Given this list of marker genes Kcnj10 (potassium inwardly-rectifying channel, subfamily J, member 10), Naip1 (NCBI Gene Id 17947), Aqp7, Dtnb, Kcnq1, Slc7a7 (NCBI Gene Id 20540), Hjv, Ptk2, Trpc4, Slc26a5, Slc8a1, Pcmt1, Clca2, Clasp2, Slc6a9, Vamp8, Inppl1, Pianp, Slc2a1, Slc16a7, P2ry2, Slc23a1, Ank3, Umod, Slc22a7, Slc22a28, Dag1, Slc3a2, Map7, Slc4a1, Slc47a2, Slc7a8, Tacstd2, Slc22a4, Gkn2, Clasp1, St14, Krt14, Slco4c1, Lrrc7, Abcc3, Tfrc, Slc4a5, Cdh1, Slc51a, Slco2a1, Lin7a, Cd46, Erbb4, Slc16a3, Slc2a9, Cldn4, Edn1, Oscp1, Hcn1, Slco1a8, Slc51b, Abca1, Slco6d1, Arrb2, Slc19a1, Mpz, Plec, Itga3, Slc7a12, Slc23a2, Map4k2, Slc9a1, Kcne3, Prom2, Slc4a11, Fap, Dsp, Stxbp3, Kcnq4, Best1, Slc43a2, Slc29a4, Atp6v1b1, Slc1a5, Atp7a, Cd38, Slc43a3, Dlg2, Akap5, Casr, Cldn11, Rapgef3, Phldb2, Slc7a1, Abcc6, Slc40a1, Slc26a11, Itga9, Cd34, Atp12a, Erbb3, Cd44, Slco6c1, Slco2b1, Cav1, Slc30a1, Adcy10 (adenylate cyclase 10), Slco1a7, Rasgrf1, Slc31a1, Folr1, Prcp, P2ry12, Ager, Ank2, Abcc10, Slc6a13, Slc22a2, Slc16a8, Aurka, Hpgd, Atp1b3, Itga2, Hsp90aa1 (NCBI Gene Id 15524), Slc22a27, Slc22a6, Fxyd5, Hspa1b, Epcam, Egfr, Slc16a1, Slc16a5, Scn3a, Dlg1, Slco1c1, Flot1, Slco3a1, Car2, Chrm3, Homer3, P2ry1, Anxa1, Trpc1, Flot2, Frmpd2, Abca8b, Slc22a19, Sctr, Cldn8, Cldn7, Ctnna2, Slc10a1, Slc39a14, Slc4a2, Megf11, S100g, Slc39a5, Bmpr2, Slc11a2, Reg1, Myo1a, Car12 (NCBI Gene Id 76459), Aqp9, Tshr, Fxyd4, Slc4a9, Ide, Muc20, Vsig1, Llgl1, Palm, Slc26a7, Erbb2, Epb41, Otof, Hsp90ab1, Pkd1, Erbin, Car9 (carbonic anhydrase 9), Slc22a3, Slc22a26, Heph, Cftr, Adora1, Kcnc2, P2ry6, Slc4a7, Slc14a1, Bsg, Adam9, Lrp1, Slc12a2, Slco1a4, B4galt1, Nkd2, Ceacam2, Ptprq, Slc16a10, Gck, Atp1a1, Tjp1, Pth1r, Kcnn4, Tgfbr1, Slc4a4, Slc16a6, Clcnkb, Lepr, Cnnm2, Cr1l, Gpihbp1, Enpp1, Tek, Rab17, Ace, Slc4a10, Slc26a6, Abcb11, Slc46a1, Gm1123, Slc12a6, Mark2, Atp7b, Entpd1, Cdh2, Kcnj4, Atp2b4, Lin7b, Slc22a8, Abca8a, Slc27a1, Slc22a1, Slc1a3, Mttp, Aqp1, Lin7c, Tlr9, Stx4a, Slco5a1 (solute carrier organic anion transporter family, member 5A1), Slc2a2, Slc14a2, Adcy8, Nedd9, Pdpn, Plpp3, Car14, Grk2, Slco1a5, Slc38a1, Slc22a30, Ezr, Ajap1, Lpo, Agtr1a, Msn, Trf, Eppk1, Pdgfb, Atp6v0a4, Ndrg4, Bsnd, Slc6a12, Clcnka, Slc6a6, Rhbg, Slc39a8, Slc16a12, Phldb1 (pleckstrin homology like domain, family B, member 1), Hfe, Cdh16, Aqp5, Vangl2, Rapgef4, Slc13a5, Best2, Wasf2, Slco4a1, Ctnnb1, Tgfa, Kcnj16, Slc8a2, Calhm3, Stk39 (serine/threonine kinase 39), Mpp4, Slc7a5, Slc22a22, Cdh17 (NCBI Gene Id 56487), Ldlr, Slc9b2, Slc13a3, Pdzd11, Marveld2, Anxa2, Slc9a4, Nod2, Calhm1, C5ar2, Dlg3, Aqp8, Slc26a1, Slc29a1, Slc47a1, Arrb1, Slc22a5, Hcn4, Clcn2, Fxyd2, Atp2c2, Cask, Dstyk, Aqp2, Eps15, Itga6, Atp2b1 (ATPase, Ca++ transporting, plasma membrane 1), Iqgap1, Slc41a1, Abcc4, Atp1b1, Cd300lg, Ceacam1, Slc17a5, Spef1, Ddr1, Atp2b2, Slc34a1, Slc29a2, Slco1b2, Slc27a5, Cd81, Ldlrap1, Cadm1, Abcc1, Numb, Aqp3, Cldn1, Met, Slc22a21 (solute carrier family 22 (organic cation transporter), member 21), Slc5a3, Clrn1, Slc38a3 (NCBI Gene Id 76257), Myo1d, Mlc1, Rhcg, Cnnm4 (NCBI Gene Id 94220), P2ry4, Itgb4, Abcc5 (ATP-binding cassette, sub-family C member 5), Aqp4, Slc22a29, Hspa1a, Pkd2, Scrib (NCBI Gene Id 54559), Itga1, Alpk2, Gm2a, Ap2a1, Nod1, Car11, Slco1a1, Orai1, C5ar1 (complement component 5a receptor 1), Myo1c, Cldn19, Cxadr, Shroom4, Slco1a6, Stx2, Slc4a8, here is a description of the gene set: species: Mus musculus The region of a cell situated near the base. For example, in a polarized epithelial cell, the basal surface rests on the basal lamina that separates the epithelium from other tissue. Mouse Gene Set: GOCC_BASAL_PART_OF_CELL